The following is a description of a gene set: studied in species Mus musculus Any biological process in an organism that recurs with a regularity of approximately 24 hours. Mouse Gene Set: GOBP_CIRCADIAN_RHYTHM, and this is the list of marker genes: Rorb, Pten, Nr1d2 (nuclear receptor subfamily 1, group D, member 2), Ghrhr, Srrd, Ncor1, Uts2, Rogdi, Ppp1cb, Kdm5b, Zpbp2, Ngfr, Mapk8, Sox14, Sin3a, Klf10, Ntrk1, Sirt6, Nms, Ntrk3 (neurotrophic tyrosine kinase, receptor, type 3), Id4, Piwil2, Scn11a, Dbp, Mta1, Naglu, Ube3a, Mup1, Kmt2a, Rai1, Mup5, Hdac3, Ghrl, Ass1, Crem, Prkaa1, Adora1, Spsb4, Zfhx3, Thrap3, Gfpt1, Ppargc1a, Drd3, Hnf1b, Casp1, Tardbp, Pasd1, Ada, Atf4, Lepr, Slc6a4, Npas2, Sirt1, Ncoa2, Gabrb3, Rbm4b, Hcrtr2, Phlpp1, Ntrk2, Ppp1ccb, Adipoq, Sik1, Ahcyl, Ppp1ca, Usp7, Mat2a, Bhlhe40, Csnk1e, Per3, Dyrk1a, Mup3, Bhlhe41, Oprl1, Hnf4a, Id3, Ccar2, Six3, Impdh2-ps, Star, Kdm2a, Nr0b2, Kcnh7, Sfpq, Cntnap2, Huwe1, Per1, Kcna2, Ndufa9, Fbxl21, Pmch, Ppp1cc, Bdnf (brain derived neurotrophic factor), Siah2, Prokr2, Hdac2, Homer1, Ddb1, Cry2, Maged1, Impdh2, Ciart, Nfilz, Magel2, Kdm8 (lysine (K)-specific demethylase 8), Aanat, Opn5, Il6, Nfil3, Cartpt, Igf1, Relb, Pparg, Nlgn3, Fxr1, Gpr157, Mapk10, Cdk1, Drd2, Mup4, Ahr, Cyp7b1, Prmt5, Nampt, Hdac1, Srebf1, Btbd9, Kcnd2, Pln, Ptger4, Usp9x (ubiquitin specific peptidase 9, X chromosome), Fbxl3, Noct, Atg7, Lep, Prkdc, Fbxw7, Nmu, Pspc1, Tnfrsf11a, Hnrnpd, Atp1a3, Mtor, Rbm4, Trp53, Mybbp1a, Cry1, Rock2, Dpyd, Bmal1, Hnrnpu, Scn9a, Prox1, Tnf, Hs3st2, Top2a, Lgr4, Prkaa2, Rora, Agrp, Pde6b, Col6a1, Suv39h2 (NCBI Gene Id 99049), Cipc, Mc3r, Atoh7, Alb, Prkg2, Btrc, Fbxw11, Gsk3b, Usp2, Creb1 (cAMP responsive element binding protein 1), Prokr1, Suv39h1, Prok1, Htr7, Prf1, Egr1, Bloc1s6, Drd4, Id1, Atf5, Kdm5a, Ces1d, Npy2r, Agrn, Per2, Cldn4, Mettl3 (methyltransferase 3, N6-adenosine-methyltransferase complex catalytic subunit), Nono, Tph1, Kdm5c, Nudt12, Rpe65, Mup11, Ppara, Mup2, Pax4, Adrb1, Prkcg, Nrip1, Ngf, Clock, Ptger3, Opn4, Crtc1, Id2, Nps, Csf2, Rorc, Ptgds, Becn1, Csnk1d, F7, Gpr176, Ddx5, Timeless, Mtnr1a, Fas, Ogt, Drd1, Setx, Egfr, Mttp, Nr2f6, Kcnma1 (potassium large conductance calcium-activated channel, subfamily M, alpha member 1, NCBI Gene Id 70528), Bmal2, Nlgn1, Parp1, Mycbp2, Ankfn1, Adora2a, Kat5, Scn10a, Nr1d1, Mapk9, Cavin3, Uts2r, Nkx2-1, Ghrh, Prkg1, Ep300, Abcb1a (NCBI Gene Id 64575), Th, Top1, Chrnb2, Adcy1, 2510009E07Rik, Ezh2 (enhancer of zeste 2 polycomb repressive complex 2 subunit), Ahcy, Tyms, Dhx9, Cort, Pml, Prok2, Mtnr1b, Nos2